The following is a description of a gene set: studied in species Homo sapiens Human Gene Set: REACTOME_INTERLEUKIN_6_FAMILY_SIGNALING Interleukin-6 family signaling, and this is the list of marker genes: LIF, OSMR, CBL, CLCF1, IL6, JAK1, IL11 (NCBI Gene Id 3589), JAK2, CNTF, IL31, OSM, STAT1 (NCBI Gene Id 6772), IL6R, IL6ST, IL31RA, CTF1, STAT3, SOCS3, IL11RA, CRLF1, CNTFR, TYK2, PTPN11, LIFR